Given this list of marker genes RNF220, PHOX2B, ZC4H2, ASCL1, INSM1, here is a description of the gene set: Human Gene Set: GOBP_NORADRENERGIC_NEURON_DEVELOPMENT The process whose specific outcome is the progression of a noradrenergic neuron over time, from initial commitment of the cell to a specific fate, to the fully functional differentiated cell. species: Homo sapiens